The following is a description of a gene set: species: Mus musculus Mouse Gene Set: MIR_155_5P from publication Chen Y, Wang X (PMID 31504780) Genes predicted to be targets of miRBase v22 microRNA mmu_miR_155_5p in miRDB v6.0 with MirTarget v4 prediction scores > 80 (high confidence targets)., and this is the list of marker genes: Smad2, Gpd1l, Pou2af2 (POU domain, class 2, associating factor 2), Ash1l, Cab39, Trappc8 (NCBI Gene Id 75964), Tshz3, Pald1, Fam135a, Rela, Tomm20, Rcn2 (NCBI Gene Id 27014), Fbxl2 (F-box and leucine-rich repeat protein 2), Cibar1, Rab34, Nr1h3, Tab2, Smug1, Mrgpra2a, Pld5, Tenm3, Gdap2, Nudt14, Tcf4, Serpina3j, Lat2, Egfr, Gpm6b, Rab11fip2 (RAB11 family interacting protein 2 (class I)), Aak1, Arid2, Cacnb4 (NCBI Gene Id 73120), Rps6ka3, Nfe2l2, Dph7, Stau2, Csf1r, Irf2bp2, Trim75, Rell1, Zfp518a, Fsd1l, Rapgef2, Map3k14 (mitogen-activated protein kinase kinase kinase 14), Rnf123, Akap10, Ndn, Fbxo11, Spef2, Smndc1, Fbxo33, Rufy2, Itk, Cebpb, 6430571L13Rik, Rreb1, Bach1, Rusf1, Acta1 (actin alpha 1, skeletal muscle), Fut9, Dync1i1, Smr3a, Lrrcc1, Jade1, Sgk3, Zic3, Card11, Mbtd1, Fam168a, Hnrnpa3, Il21, Zkscan3, D5Ertd579e, Bmal1, Psip1, Mctp1, S1pr1, Washc4, Gzf1, Sfpq, Antxr2, Myo1d, Stxbp5l, Arhgap18, Aicda, Fgf7, Ptpn2, Ikbke, Hbp1, Smarca4, Grip1, Syvn1, Csnk1g2, Olfml3, Pramel27, Kdm7a, Bnc2, Smim13, Etv3, Zfp652, Trp53inp1, Sema5a, Gria2, Pkn3, Boc, Ets1, Cops3, Cacul1, Emp2, Tle4, Wsb1, Kpna1, Dcun1d3, Bpifb2, Usp9x, Tspan14, Sdcbp, Carhsp1, Trim32, Fgf16, Traf3, Pskh1, Psmb6, Tbr1, Rps6kb1, Vezf1, P2ry10b, E2f2, Wee1, Raver2, Grhpr (glyoxylate reductase/hydroxypyruvate reductase), Pigm, Mier3, Zfp407, Jarid2, Rps6ka5, Ecm2, Lgalsl, Tmem267, Ass1, Lrrc59, Inpp5d, Atxn1l, Tnip3, Actl7a, Hivep2, Clock, Spi1 (NCBI Gene Id 20375), Cacna2d1, Dhx40, Rab6a, Terf1, Pkn2, Jpt2, Mybl1, Det1, Pea15a, Myb, Wbp1l, Mef2a, Apol10b, Lrrk2, Kansl1, Il15ra, Mrgpra2b, Lcorl, Smim26 (NCBI Gene Id 277433)